The following is a description of a gene set: C57Bl/6 wild-type and STAT6 KO mice were used to study PPARg and IL-4 signaling. Bone marrow of 3 mice per group was isolated and differentiated to macrophages with M-CSF (20 ng/ml). 20 ng/ml IL-4 was used to induce alternative macrophage activation and 1 uM Rosiglitazone (RSG) was used to activate PPARg. From each mouse 4 samples were generated: 1. M-CSF, 2. M-CSF+RSG, 3. IL-4 and 4. IL-4+RSG. All compounds were added throughout the whole differentiation process, and frech media was added every other day. Control cells were treated with vehicle (DMSO:ethanol). After 10 days, RNA was isolated and gene expression profiles were analyzed using Mouse Genome 430 2.0 microarrays from Affymetrix. studied in species Homo sapiens from publication Szanto A, Balint BL, Nagy ZS, Barta E, Dezso B, Pap A, Szeles L, Poliska S, Oros M, Evans RM, Barak Y, Schwabe J, Nagy L (PMID 21093321) Human Gene Set: GSE25088_IL4_VS_IL4_AND_ROSIGLITAZONE_STIM_STAT6_KO_MACROPHAGE_DAY10_DN Genes down-regulated in bone marrow-derived macrophages with STAT6 knockout treated with IL4: control versus rosiglitazone., and this is the list of marker genes: CXCL16, SOCS1, ELF1, USF3, F3, TMED10, PLSCR1 (NCBI Gene Id 5359), PLEKHM2, SERPING1, TNFSF14, SP140, MB21D2, PNPLA8, LGALS1, ATP13A3-DT, TBK1, MS4A4A, HSP90AA1, IER3, PIK3AP1, BAALC-AS2, RIMOC1, HLA-DOB, HNRNPC, GHRL, SINHCAF, PTGER2, HSPA5, RAB1A, UBR1, RCHY1, RELA, DNAJB11, ANXA7 (annexin A7), FLCN, CCDC59, AK4 (NCBI Gene Id 387851), PIK3R5 (phosphoinositide-3-kinase regulatory subunit 5), ZEB2, TAP2, UBE2Z, SRC, ITGAV, DDX21, LPCAT1, MT1G, MAP4K4 (NCBI Gene Id 9448), PNRC1, PRPF40B, MGAT1, PIM2, RAB13, CD63, GNLY, DDIT3, OSTM1, BHLHE40, C16orf87, BATF2, G3BP2, NPR3, LCN2, WTAP, ARF4 (ADP ribosylation factor 4), ARHGEF10L, MAML2, SNX10, SASH3, BRD2, CHI3L2, ZC3H11A, SPINT2, TOMM40L, IL10RA, PRELID3B, WSB1, SLC25A13, MT1F (NCBI Gene Id 4494), MAP2K1, GARS1, BTBD19, IFIT3, DUSP5, ARL5B, CFB, TFRC, SCARF1, SLC7A7, CEPT1, ADAM17, OGFRP1, IL1R1, PSMA1, LAIR2, GTF3C6, MRPL21, STT3A, SCN1B, PDIA6 (protein disulfide isomerase family A member 6), SOD2, ZCCHC2, MYBPH, STAT5A, PSMB4, FGR, SLFN11 (schlafen family member 11), CYSTM1, ETS2, TAB2, TRAF3, ZNF274, SLCO4A1, MGLL, OAS3, NFKB1, ARMCX3, IFIT1, PROCR, IL4I1 (NCBI Gene Id 259307), CCDC93 (coiled-coil domain containing 93), FNDC3B, DDX60, NRIP3, EBI3 (Epstein-Barr virus induced 3), P4HA1 (NCBI Gene Id 5033), ATP10D, RPL36AL, ATP6V1G1, CIR1, C5orf15, EAF1, STEAP1B, LACC1, ABCC1, CPEB4, ADNP2, SLC1A3, EML2, SERPINB8, JAKMIP2, SPART, MAFG, BCL2A1, INHBA, P2RY14, MFAP1, CKAP2L, SPHK1, HMGN2P46, CARD16, NRIP1, MTF1, VAV1, MT1E, DAP, P2RX4, EIF1B, UNC50, OSTC, RBM18, TBC1D7, IER5, CEMIP, CHST7, RNF144B, RABGEF1, IL15RA, TRAM1, DUSP16, IL1A, HCCAT5, HRH1, MCTP1, PILRA, LYN, RETN, SEC22B, DTX3L, RRAGC, PRF1, CXCL5, SH3BP5, ZNF438, NR4A3, TNFAIP2, IFIH1, ACOT9, INSIG1, ATG7 (autophagy related 7), SLC22A18AS, EIF2AK2, MRGPRX3, GK3, SLC16A10, PRKAG2-AS2, GBP3, NFKB2